Given this list of marker genes RAB3A, SYTL4, ANXA2, S100A10 (S100 calcium binding protein A10), MYH9, AHNAK, CASP7, here is a description of the gene set: Human Gene Set: GOBP_REGULATION_OF_PLASMA_MEMBRANE_REPAIR species: Homo sapiens Any process that modulates the frequency, rate or extent of plasma membrane repair.